Given this list of marker genes Plekha7, Rspo1, Tbc1d12, Ireb2, Pclo, Cxcl12, Larp4b, Cd300a, Acer1, Sh3kbp1, Sh3gl2, Angpt2, Pglyrp2, Dhrs9, Nfatc2ip, Eln, Itgav, Ppm1m, Prokr2, Fnd3c2, Dbp, Kcnn3, Gcnt2 (glucosaminyl (N-acetyl) transferase 2 (I blood group)), Gtf2i, Tm9sf3, Krtap13-20, Rapgef6, Tmem47, Fancm, Pcgf3, Kctd9, Spn, Dynll1, Col4a6, Col11a1, Gpm6a, Adam19, 6430550D23Rik, Gfod2, Tmem33, Nuak1, Steap2, Ypel5, Gsg1l, Arhgef15, Atl2, Hecw2, Gm15881, Drp2, Itih5 (NCBI Gene Id 78501), Mrps10, here is a description of the gene set: species: Mus musculus from publication Chen Y, Wang X (PMID 31504780) Genes predicted to be targets of miRBase v22 microRNA mmu_miR_6906_5p in miRDB v6.0 with MirTarget v4 prediction scores > 80 (high confidence targets). Mouse Gene Set: MIR_6906_5P